Given this list of marker genes CNTRL, ERLIN2, BCR, FGF23 (fibroblast growth factor 23), FGF9, FGF2, LRRFIP1, PIK3CA (NCBI Gene Id 5290), ZMYM2, MYO18A, FGF4, FGF6, FRS2, STAT5A, SOS1, PLCG1, GAB2, STAT5B, FGFR1OP2, FGF1, PIK3R1, STAT1, KRAS (NCBI Gene Id 3845), GAB1, CUX1, FGF20, FGF8, FGF17, FGFR1, GRB2, BAG4 (BAG cochaperone 4), FGF5, CEP43, TRIM24, CPSF6 (NCBI Gene Id 11052), STAT3, HRAS, NRAS, here is a description of the gene set: Human Gene Set: REACTOME_SIGNALING_BY_FGFR1_IN_DISEASE Signaling by FGFR1 in disease species: Homo sapiens